Given this list of marker genes Etnppl, Vdac1, mt-Tq (mitochondrially encoded tRNA glutamine), Pdhx, Mrpl32, Dctpp1, Gsdmd, Cln8 (NCBI Gene Id 26889), Mtch2, Agk, Crot, Reep1 (receptor accessory protein 1), Eral1, Gpx1, Atp5f1a, Acsbg2, Mobp, Ndufs7, Slc30a2, Nubpl, Ndufaf5, Pet100, Bltp1, Mrpl34, Ppp1cc, Miga2, Yme1l1, Tmem177, Afg1l, Ehhadh, Stmp1, Tnrc18, Tmtc1, Hsd17b8, Grsf1, Gfm1, Ak3, Ddit4, Smad5, Slc9b2, Rida, Mavs, Eci2, Ddah2, Tmbim6, Pnpla8, Polr1g, Cyp2e1, Nme2, Aqp8, Dmgdh, Trim27, Hsd3b3, Slc25a36, 4933434E20Rik, Slc1a3, A830073O21Rik, Rap1gds1, Htra2, Pde2a, Nol3, Tmem14c, Trim34b, Vamp1, Fmc1, Coq5, Anxa10, Mrps26, Cryzl2, Txnrd2, Usp48, Wdr81 (NCBI Gene Id 192652), Pmpca, Tmem11, Timm29, Fkbp8, Secisbp2l, Aldh2, Pgs1, Slc27a1, Ldhb, Hoga1, Fastkd3, Fundc2b, Mrpl10, Pde12, Sphkap, Mgme1, Hax1, Acp6, Fdx2, Uqcr10, Tsfm, Ckb, Sting1 (NCBI Gene Id 72512), Spire1, Immp2l, Afg3l1, Atp6v1a, Nr3c1, Tmem65, Mcee, Bdh1, Tug1, Tomm70a, Got2, Slc9a1, Coasy, Slc25a53, Chchd1, Tppp, Ybey, Rilp, Rala, Tdrkh, Lgals3, Rpl35a, Rnaset2a, Acod1, Cox14, Stx17, Agmat, Cyp2d11, Dnajc11, Pmpcb (peptidase (mitochondrial processing) beta), Hspa9, Ykt6, Stard13, Ndufa4, Vdac2 (NCBI Gene Id 22334), Bcl2a1b, Ppp3ca, Cox8b, Oxct2a, Uqcc5, Mff, Atad1, Ldha, Kyat3, Ntrk1, Fkbp4, Bcl2a1d, Aifm1, Cdkn2a, Fbxw7, Timm50, Capn10, Adcy10, mt-Tm, Tfb2m, Usp15 (NCBI Gene Id 70921), Chdh, Bltp2, Aldh4a1, Zfp13 (NCBI Gene Id 240046), Nt5dc3, Mipep, Cryab, Dglucy (D-glutamate cyclase), mt-Tl2, Ccr7, Cox20, Fndc1, Isca2, Prnp, Gsk3a, Cwc15, Slc25a1, Nmnat3, Rab3d, Uba1, mt-Tf, Yjefn3 (YjeF N-terminal domain containing 3), Slc25a46, Mecr, Me1, Plin5, Sdhc, Ywhaz, Mthfd1 (methylenetetrahydrofolate dehydrogenase (NADP+ dependent), methenyltetrahydrofolate cyclohydrolase, formyltetrahydrofolate synthase), Dcps, Higd1c, Mapk3, Jtb, Ptcd1, Dhfr, Nars1, Trap1, Gstk1, Acsl5, Etfdh, Poldip2, Slc25a12, Prr5l, Azin2, Slc29a3, Slc25a22, Dbi, Fam210a, Pi4kb, Nipsnap1, Nlrp3, C330018D20Rik, Mterf1a, Srgap2, Hsd3b5, Kansl1, Afg3l2, Dhrs4, Ngb, Ambra1, Vps13a, Mapk10, Gtpbp10, mt-Nd3, Ccn6, Msra, Isoc2a, Pars2, Bri3bp, Gls2, Rab11fip5, Ciapin1 (cytokine induced apoptosis inhibitor 1), Adh5, Sdsl, Vamp8, Snca, Alkbh3, Mrps23, Hsdl2, S2bpcox16, Ucp1, Ndufa6, Mrps12, Hrk, Plgrkt, Nsun2, Dtymk, Slc25a30, Ogt, Snd1, Park7, Tpo, Cox7a2l, Slc9a6, Rab7, Cyp27b1, Mtarc1, Tardbp, Gpd1 (glycerol-3-phosphate dehydrogenase 1 (soluble)), Efhd1, Nol7, Arid4b, Pusl1, Mtrf1l, Pstk, Tst, Timm9, Pam16, Serac1, Car5b, Mrpl30, Ndufaf8, Pemt, Abcg1, Agr2, Tk2, Ndufaf2, Gpx4, Phb2, Noc3l, Dmac2, Bik, Cisd1, Aldoc, Ccs, Gsta1, Kars1, Elk1, Pyroxd2, Cstad (CSA-conditional, T cell activation-dependent protein), Mrpl13, Abcb1b (ATP-binding cassette, sub-family B member 1B, NCBI Gene Id 18669), 4930550C14Rik, Sarm1, Ctsa, Ifit3 (NCBI Gene Id 433243), Secisbp2, Akr7a5, Zfhx3, Etfrf1, Kansl2, Mrs2, Cox10, Ndufs4, Ndufb4b, Wars2, Bcl2l2, Mtg1, Gng5, Hyou1 (hypoxia up-regulated 1), Araf, ENSMUSG00000125816, Hspa5, Pisd, Mrpl16, Aco2, Top1mt, Gtpbp8, Qtrt1, Acat1, Uqcc6, Hsd3b9, Acot2, Rab11fip3, Akr1b8, Chchd3, Ugt2b37, Htd2, Smpd5, mt-Atp6, Rab38, Myoc, Pdk1, Acads, Mrm2, Ddx21, Nipsnap3b, Cox7c, Sdha, Glod4, Amt, Alkbh1, Atp5mk, Supv3l1, Pxmp2, Adap2, Adh1, Polr2b, Mrps2, 2310002L09Rik, Aars1, Fkbp10, Msrb2, Rab40b, Tshz3, Pln, Kynu, Abcd2, Gstm1, Fxn, Mmachc, Irgm1, Oas1c, Ndufc1, Gldc, Nthl1, Ier3, Adck5, Psma6, Gsdma3, Coa6, Fh1, Fam72a, Lap3 (NCBI Gene Id 66988), Uqcr11, Casp9, Fpgs, Ndufb4c, Samm50, Ecsit, Akt1, Cyp2d22, Gfm2, Neurl4, Tmem8b, Dgat2, Thop1, Rsad1, Cox17, Ntrk3, Fth1, Rfk, Slc30a7, Sod2, Sardh, Brd8, Cyp27a1, Pcbd2, Cyp11b1, Crebzf, Gsta4, Slc25a31, Bnip3l (NCBI Gene Id 97931), Pck1, Mrpl12, Prkce, Pdss1, Arg2, Gapdh, Exd2, Mrpl18, As3mt, Klc2, Braf, Dlat (NCBI Gene Id 235339), Slc16a1, Rps6ka6, Plaat3, Prelid3b, Cfap410, Aldh5a1, Nsun4, Mgst1, Pgam5, Lonp1, mt-Tg, Trnt1, AK157302, Timm8a2, Immp1l (IMP1 inner mitochondrial membrane peptidase-like (S. cerevisiae)), Cox6c2, Qtrt2, Mapk8ip1, Disc1, Tmem242, Cnr1, Mdh1, Napg, Metap1d, Cyp11b2, Emc2, Acly, Kmo, Slc25a29 (NCBI Gene Id 353077), Dck, Acsf3, Ppp6c, Apex1, Acad8, Slc25a40, 1700066M21Rik, Tmem223, Slc25a35, Akap1, Coa3, Sncb, Src, Timm17b, Mtor, Cps1, Agxt, Rars1, Rmdn2, Smim30, C030010C08Rik, Fzd9, Dnlz, Ptges2, Vasn, Mars1, Ndufa7, Ppa2, Uqcc3, Plscr3, Dcaf8, Ugt2b5, Nadk2, Gpt2, Cox6b2, Fastkd1, Cbr4, Rhoa, Gcat, Rps3 (NCBI Gene Id 52418), Asl, Adam28, Gja6, Pycr2, Nrdc, Acot9, Dnaja1, Prdx6b, App, Mrps27, Rnasel, Spr, Agxt2, Sfxn3, Nudt1, Phyhipl, Arl2bp, Slc25a48, Spmip6, Ammecr1, Tmem102 (NCBI Gene Id 380705), Ung, Chchd5, Mrpl36, Ndufb3, Mrps11, Slc25a33, Gabbr1, Nefh, Nat8f1, Ctps2, Cuta, Rab32, Kcnq3, Ywhah, Coa7, Pdss2, Drg2, Nme1, Taco1, Slc25a37, Rai14, Asb9, Trit1, Mrpl46, Brinp3, Aadat, Pccb, Ifi27l2a, Agpat5, Rab11b, Sox4, Heatr1, Nars2, Nrgn, Tusc3, Glyat, Mfsd8, Atp5po, Cyct, Coa8, Urah, Oma1, Phykpl, Slc30a9, Tmem71, Camk2a, Rxra, Kifbp, 2310061I04Rik, Dusp26, Slc25a28, Cox19, Slirp, Abcd1, Fen1, Dusp18, Pcf11, Mrpl58, Mtcp1, Mtnap1, Mapk12, Maip1, Etfbkmt, Rpl34, Bag5, Tfam, Plpbp, Arglu1, Slc25a10, Dbt, Mrpl47, Sars2, Sdhaf1, Ndufb4, Phb1, Sdhb, Agtpbp1 (ATP/GTP binding protein 1), Xpc, Slc25a51, Dld, Aars2 (alanyl-tRNA synthetase 2, mitochondrial), Atp5pf, Triap1, mt-Te, Aurkaip1, Shmt2, Slc25a54, Bckdha, Mpv17l2, Mrpl3, Spata18, Pla2g2a, Slc27a3, Higd1a, Polr2a, Dmac1, Hagh, Haao (NCBI Gene Id 71669), Polg2, Mtrf1, Mtarc2, Map2k1, Fam162a, Fsip2, Rnf144b, Otc, Samd9l, Isoc2b, Cyp1a1, Apoo (NCBI Gene Id 73714), Ncbp1, Cfap91, Gckr, Myg1, Fahd2a, Ngdn, Hif3a, Degs1l, Cisd3, Flad1, Oxct2b, Mrps35 (mitochondrial ribosomal protein S35), Ppp1r15a, Adprs, Armcx3, Acaa1b, Atp5f1e, Tcaim, Shc1, Helb, Mief1, Acbd3, Sdhaf2, Sdhaf4, Acot8, Tafazzin, Slc25a42, Hmgcl, Ogdhl, Mcur1, Tspo, Arg1, Gcdh, Dok7, Hspa1a, Clic1, Ndufb6 (NCBI Gene Id 277815), Lipe (NCBI Gene Id 71060), Mtx2, Ccnb1-ps, Nacc2, Xpnpep3, Slc35f6, mt-Cytb, Mrpl57, Hsd3b1, Traf3 (TNF receptor-associated factor 3), Pdha2, Piwil4, Ap2m1, Ckap4, Ndufa11, Sqor, Tmigd1 (transmembrane and immunoglobulin domain containing 1), Clpb, Abl1, Lyn (NCBI Gene Id 99963), Coq7, Acaca, Aldh9a1, Arhgap26, Nlrp5, Sirt5, Acsl3, Slc22a4 (NCBI Gene Id 56507), Tufm, Ckmt1, mt-Nd4 (NCBI Gene Id 98546), Sp140l2, Stard4, Thg1l, Msto1, Ndufs5, Stard7, Atp5mc3, Fem1al, Sirt4, Tbc1d15, Coq8b, Hspa1b, Ociad1, Rnaseh1, Fastkd2, Mrps6, Eln, Lyrm4, Pgk1, Lpin1, Rdh13, Ncoa4, Them7, Mtfp1, Slc11a2 (NCBI Gene Id 18174), Nme3, Eci1, Slc25a21, Gpd2, Mrpl2, Ikbke, Pla2g6, Gtpbp3, Bad (NCBI Gene Id 12015), Nudt8, Chpf, Dcakd, Ndfip2, Erbb4, Mdh2, Xrcc3, Mmaa, Mrpl28, Bcl2l11, Pacrg, mt-Tl1, Gstp1, Fastk, Rmnd1, Mrpl54, Nudt19, Nos1ap, Pmaip1, Slc25a34, Clic5, Slc8b1, Miga1, Sult4a1, Vrk2, Abca9, Fdx1, Stap1, Prdx1, Spryd4, Tbrg4, Acat2, Bak1, Parp9, Mapk8, Calr (calreticulin), Prorp, Grk2 (NCBI Gene Id 11557), S1pr4, Depp1, Bbc3, Acadl, Ivd, Chchd4, Cyp2d10, Cyp2d9, Atpaf1, P2rx7, Ubc, Ass1, Atg4d, Aass, Sqstm1, Mrpl44, Nnt, Rab4b, Atp5mj, Cyp17a1, Gsta2, Nudt13, Tmx2, Cyb5r3, Sgk1, Dhx29, Acad10, Atg9a, Mtx3, Mrps7, Nxnl1, Hmga1, Pdpr, Slc30a6, Slc27a2, Stard3, Mcl1, Mrpl51, Sox10, Acss1, Trmt5, Ndufab1, Hsp90aa1 (NCBI Gene Id 15524), Coq6, Dhx36, Tpp1, Mars2, Ndufab1-ps, Sod1, Clpx, Rdh14, Pank2, Khdc3, Casp8, Elk3, Ctsd, Atp5pd, Iars2, Emc8, Tsc22d1, Slc25a27, Coq3, Coa4, Hint2, Fundc2, Acyp2, Sfxn4, Romo1, Zbtb6, Tamm41, Cyb5b, Cavin1, Creb1, Bcl2l10, Dnajc19, Parp1, Rps15a, Pla2g4f, Fam110b, Creb3l4, Brca1, Tspoap1, Prdx5, Ndufb11, Bckdk, Rps6kb1, Abhd12, Hsp90ab1, Mrpl19, Trmt2b, Vwa8, Slc22a14, Cox5b, Tax1bp1, Car5a, Atp6v1e1, Rad51 (RAD51 recombinase), Iscu (NCBI Gene Id 66383), Mtx1, Tango2, Hkdc1, Rbfa, Polg, Atp5f1d, Oas1h, Cox7b2, Lyrm1, Csl, Hmgn5 (high-mobility group nucleosome binding domain 5), Hdhd5, Atp10d, Vps25, Pak5, Fn3k, Mpo, Ccnb1, Lypla1, Mapk9, Nelfb, Nudt9, Aldh1b1, Casq1, Atpsckmt, Parl, Hk2, Ttc5, Gclc, Ppif, Kansl3, Atp5mg, Armcx1, Idh1, Qdpr, AU015836, Map1lc3b (NCBI Gene Id 67443), Ankrd37, Sco2, Akap10, Oas1b, Txnrd3, Mrpl11, Top3a, mt-Tw (mitochondrially encoded tRNA tryptophan), Cabs1, Pex11b, Sccpdh, Bcat1, Gmppb, Hip1r, Cldn34c5, Adss2, Gatm, Abhd10, Mtln, Nt5m, Acox3, Vps54, Dmpk (dystrophia myotonica-protein kinase), Cox5a, Trabd, Gk (glycerol kinase), Cidea, Atic, Abcb8, Tert, Cybb (cytochrome b-245, beta polypeptide), Gpaa1, Acat3, Golph3, Pts, Atp5me, Bnip1, Fastkd5, Drd4, Tex10, Dhodh, Hao2, Lrrc10, Hspe1-rs1, Gsta3, Mpc1, Slc3a1, Cerk (ceramide kinase), Atp5mc2, Fitm2, Atp5f1b, Ddx28, Slc25a14, Bola3, Hspb6, Ndufa5, mt-Nd4l (NCBI Gene Id 17720), Dusp21, Slc22a3, Fem1a, Galc, Nt5c3, Mpv17, Mterf4, Ptpn1, Pla2g15, Gatc, Polr1b, Pigbos1, Slc25a20, Slc25a38, Mix23, Cars2, Dars2, Bid (BH3 interacting domain death agonist), Mxd1, Ifi27 (interferon, alpha-inducible protein 27), Sirt2, Selenoo, Tfap2c, Oprk1, Chchd7, Chat, Ndufb1, Lrpprc, Acsl4, Macrod1, Uqcrc2, Acsm2, Hsd3b8, Hspa2, Hibch, mt-Tc, Fam136a, Ddx1, Mtfmt, Nipsnap2, Dmd, Comtd1, Pdk4, Pif1 (PIF1 5'-to-3' DNA helicase), Stk11, Calm3, Timm21, Siva1, Ghitm, Plekhn1, Ambp, Ndufb8, Trp53 (NCBI Gene Id 22059), Bcl2a1c, Bcl2, Tchp, Anxa1, Nfs1, Trim14, Ppox, Mrps9, Rab35, Timm22, Cep89, Gch1, Rexo2, Twnk, Hebp2, Slc25a17, Rack1, mt-Ts2, Hccs, Snn, Pus10, 4933405O20Rik, Nt5c (5',3'-nucleotidase, cytosolic), Canx, Abhd11, Kat8, AA467197, Ddah1, Mrpl21, Nit2, Ugt1a6a, mt-Tt (NCBI Gene Id 17744), Ggnbp1, Acad12, Opa3, Nfkb1, Irgm2, Mrpl41 (NCBI Gene Id 20007), Cry2, Sfxn5, Gck (NCBI Gene Id 14624), Pdk3, Foxk2, Fbxl4, Rab8b, Rnf5, Ogdh, Polr1a, Sphk2, Dnajc30, Fam210b, Ndufb9, Dctn6, Tars3, Mrpl48, mt-Ta, Micu2 (mitochondrial calcium uptake 2), Yap1, Psen1, Dhx30, Dlst, Mrpl37, Synj2bp, Foxo3, Znfx1, Pycard, Csde1 (NCBI Gene Id 99530), Slc25a41, Fancg, Tmem160, Nudt2, Eny2, Nampt, Cyc1, Immt, Uqcrq (ubiquinol-cytochrome c reductase, complex III subunit VII), Cisd2, Grpel1, Zdhhc8 (zinc finger, DHHC domain containing 8), Pla2g4c, Qrsl1, Mrps17, Nln, Prxl2a, Raf1, mt-Ts1, Nipsnap3a, Txn1, Tstd1, Rab29, Bnip3l-ps, Timm17a, Selenon, Pitrm1, Ears2, Slc25a45, Rars2, Tmem256, Ifit3b, Glrx, Uqcrc1, Pycr1, Mtg2, Wwox, Mlycd, Atg4b, Slc25a47, Gimap8, Suclg1, Mmab, Pkm, Acacb, Pi4k2a, Acox1, Tomm34, Atg13, Aifm3, Smurf1, Hsdl1, S100a1 (NCBI Gene Id 99575), Lias, Pdpn, Ireb2, Ercc6l2, Letmd1, Cfh, Uqcrh-ps1, mt-Nd2, Mterf3, Atp5mc1, Klc3, Slc25a15, Sds, Txnrd1, Stxbp1, Mrpl45, Hdhd3, Pdp1, Dpysl2, P4ha1, Pnpt1, Ndufs8, Cfl1, Capn1, Pin4, Myo19, Ubqln5, Lyrm7, Bloc1s2, Ap3b1, Acadvl, Pcca, Aldh1l1, Oxld1, Vps35, Oas1e, Ndufb11b, Mrpl43 (mitochondrial ribosomal protein L43), Cox11, Prodh2, Mrm3, Etfa, Pld6, Mrps15, Hadha, Rsad2, Map2k2, Pet117, Grn, Pdzd8, Ndufaf7, Abat, Slc25a2, Gstz1, Agps, Surf1, Gpn1, Fdps, Prdx4, Maob, Ppargc1b, Ptrh1, Trmt10c, Ift140 (intraflagellar transport 140), Iqcn, Trub2, Nif3l1, Cox7b, Abcb10, Ethe1, Uox, Cbr2, Ptcd3 (pentatricopeptide repeat domain 3), Nox4, Cend1, Acss3, Pebp1, Dhrs2, Hsd17b4, Pyurf, Lyrm2, Slc41a3, mt-Nd1, Gstm2 (glutathione S-transferase, mu 2), Pou5f1, Atxn3 (ataxin 3), Atpaf2, Slc25a3, Zfyve1, Hscb, Spata33, Idh3g (NCBI Gene Id 15929), Eci3, Rhbdd1, Katnal1, Prdx6, mt-Tv, Serhl, Msrb3, Plcd1, Ern1, Mtus1, Higd2a, Hddc2, mt-Co1, Haus3, Trak2, Mtres1, Mettl4, Dnajc27, Mthfd1l, Cyp2u1, Cpt1a, Ndufaf4, Hibadh, Slc25a26, Cox16, Hsd3b4, Acsm1, Hars2, Ndufc2, Nsun3, Slc25a39, Mmut, Dele1, Mto1, Clybl, Tigar, Nags, Snph, Yars2, C030006K11Rik, Ech1, Sfxn2, Cyp2d26, Vps13c, Hsd3b2, Ttc19 (NCBI Gene Id 76693), Pink1, Ndufaf6, Atg5lrt, Plaat1, Akr1b10, Echdc3, Timmdc1, Mthfsl, Adck1, Rhot1, Alpl, Sh3bp5, Ide, Gps2, Dnm3, Hivep1, Cert1, Calm1, Oprm1, Glud1, Micu1, Them4, Prelid3a, Sirt3, Mapk1, Slc25a32, Acadm, Sdhaf3, Kif1b, Coq8a, Asah2, Bphl, Becn1, Pck2, Gimap3, Ngrn, Abca8b, Lactb2, Tomm7, Adsl, Oas1d, Macc1, Ndufv2, Lipt1, Usp30, Ptgr2, Tmem14a, Hspe1, Prkca, Clpp, Hlcs, Sult1c2 (sulfotransferase family, cytosolic, 1C, member 2), Naif1, Tmco1, Atad3a, Prelid2, Letm2, Uqcc4, mt-Tk, Tyms, Cox15, Them5, Mrpl23, Mthfd2l, Slc25a18, Crym, Gk2, Nos1 (NCBI Gene Id 76730), Ticam1, D2hgdh (D-2-hydroxyglutarate dehydrogenase), Mrps24, Hspd1, Guf1, Ptpmt1, Cyb5r2, Flvcr1 (feline leukemia virus subgroup C cellular receptor 1), Rab11a, Pick1, Uqcc1, Tat, Ccm2, Bclaf3, Bcat2, Ndufaf1 (NCBI Gene Id 69702), Rrm1, Vat1, Cebpzos, Irf3, Micos13, Chchd2, Rab24, Mthfs, Ociad2, Nol6 (nucleolar protein family 6 (RNA-associated)), Abhd5, Coq2, mt-Co3, Ndufb2, Polr3b, Bola1, Mcat, Tomm40, Th, Noct, Pla2g4b, Tomm6, Oxa1l, Apex2, Mycbp, Abcf2, Suox, Ndufv1, Mtch1 (NCBI Gene Id 98058), Tusc2 (tumor suppressor 2, mitochondrial calcium regulator), Cry1, Prkaca, Cs, Coa5, Cmc2, Slc25a13, Nudt6, Atcay, Uqcrh, Hspa1l, Glrx2, Vars2, Tmem126a, Gls (NCBI Gene Id 98298), Mrm1, Anxa6, Cpt2, Micu3, Cyb5a, Pnkd, Tmx1, Glyatl3, Ccdc51, Hs1bp3, Casp8ap2, Cox8c, mt-Td, Acad9, Prickle3, Psap, Spg7, Stat3, Abcc9, Nfu1, Sucla2, Slc25a16, Mrpl15, Idh2, Acaa1a, Iqce, Cpne3, Wdr26, Abcd3, Acsm4, Cyp1b1, Igtp, Slmap, Arhgap11a, Cdk1, Mat2b, Nlrx1, Gpam, Hadh, Adhfe1, Mrpl50, Star, Naxd, Gadd45gip1, Septin4, Dnajc4, Dnm1l, Ifi27l2b, Cyb5r1, Chchd10, Noa1, Casp1, Acsm3 (acyl-CoA synthetase medium-chain family member 3), Malsu1, Coq10b, Olfm4, Me3, Timm44, Spart, Lig3 (NCBI Gene Id 28083), Crat, Ifih1, Gm6559, Aldh6a1, Ogg1, Mpst, Stom, Kif5b, Ppm1j, Idh3b, Nme4, Styxl1, Shmt1, Ndufa12, Tomm40l, Armc12, Uqcc2, mt-Tp, Gk5, Cyp2b10, Ndufa9, Abcb7, Kif28, Lipt2, Cox7a1, Dact2, Pptc7, mt-Atp8, Sfxn1, Arl2, Mmadhc (methylmalonic aciduria (cobalamin deficiency) cblD type, with homocystinuria), Pus1, Ripk1, Slc39a9, Gramd4, Me2, Cdc25c, Cdk5rap1, Oxr1, Ndufa11b, Armcx6, Fis1, Slc25a25, Mrpl33, Acsm5, Tgm2, Pcx, Glyctk, Tmem135, Acot1 (acyl-CoA thioesterase 1), Cox18, Hpdl, Slc35b3, Ppp3cc (protein phosphatase 3, catalytic subunit, gamma isoform), Pex5, Mrps18a, Rmdn3, Nbr1, Tars2, Uxs1, Afg2a, Glul, Ywhag, Hadhb, Gper1, Bnip3, Sh3glb1, Mief2, Fhit, Chchd2-ps, Hmgcs2, Bco2, Epha4, Gars1, Sugct, Mfn2, Ralbp1, Atp5f1c, Sco1, Cpox, Cyp2d12 (cytochrome P450, family 2, subfamily d, polypeptide 12), Bcs1l, Tmem126b, Cmpk2, Clic4, Abhd8, Nat8l (NCBI Gene Id 68762), Ak2, Mrpl27, Ldhd, Echs1, Cnp, Ldhc, G0s2, Cox6c, Cibar1, Cyba, Ppm1m, Mrpl14, Hk3, Ptrh2, Vdac3, Phyh (phytanoyl-CoA hydroxylase), Mrpl1, Crls1, Mmp3, Rpusd4, Gatd3a, Hap1, Pdha1, Rtn4ip1, Tomm20l, Timm10, Gja1, Timm10b, Rad51c, 2310057M21Rik, Cmc4, Cycs, Trim39, Plec, Polrmt, Nenf, Slc25a24, Stoml2, Angel2, Eif2s1, Slc25a5, Prelid1, Mrpl53, Mapkap1, Mtfr1l, Dnajc19-ps, Timm13, Tomm22, Smim20, Mrpl39, Polq, Dus2, Mtfr1, Fyn, Clu, Slc25a44, Aldh7a1, Ndufa2, Gpat2 (glycerol-3-phosphate acyltransferase 2, mitochondrial), Rab1b, Cat, Sp140l1, Osgepl1, Acot10, Cyp24a1 (cytochrome P450, family 24, subfamily a, polypeptide 1), Mettl9, Primpol, Lactb, Atp5pb, Cox6b1, Mrpl38 (mitochondrial ribosomal protein L38), Auh, Oas1g (NCBI Gene Id 23960), Cox7a2, Prdx2, 1700123O20Rik, Gcsh, Ppm1k, Ssbp1, Dhrs1, Ucp2, Ube3b, Ndufa3, Neu4, Mrps25, Gdap1, Trmu (tRNA 5-methylaminomethyl-2-thiouridylate methyltransferase), Decr1, Elac2, Mrps5, Lipf, mt-Ti, Sgpp1, Rmdn1 (NCBI Gene Id 78089), Pdp2, Pacs2, Grpel2, Mrps21, Mgst3, Gfer, Mrps28, Gsk3b, Tomm5 (translocase of outer mitochondrial membrane 5), Jarid2 (NCBI Gene Id 97879), Wasf1, Cltc, Mtpap, Pdf, Rps14, Fdxr (ferredoxin reductase), Cox6a2, Isca1, Uqcrb, Pdhb, Rpusd3, Mtif3, Ank2, Ccdc90b, Cct7, Bok, Cmc1, Slc25a43, Mrpl40, Prkn, Degs1, Mrps22, Mpc2, Nit1, Col6a1, Keg1, Tmem186, Caprin2, Spata19, Dcaf5, Sdhd, Gstp-ps, Mcu, Aldh1l2, Mrps18c, Higd1b, Fars2, Eefsec, Kyat1, Bbox1, Mrps16, Rnf185, Yrdc, Tefm, Proca1, Mtif2, Casp14, Uqcrfs1, Mrpl22, Aldh18a1, Xaf1, Ak4, Ndufb5, Lrp5, Dut, Stpg1, Ndufb10, Gsr, Sirt1 (NCBI Gene Id 93759), Tcirg1, Ndufa8, Idh3a, Mrpl20, Nod2, Tatdn3, Ccdc136 (coiled-coil domain containing 136), Cyp2d34, Abce1, Aldh3a2, Dip2a, Coq10a, 1600014C10Rik, Vars1, Mettl17, Lrrc59, Mtfr2, Mrpl9, Cpt1b, Alkbh7, Fcor, Comt, Tap1, Diablo, Chchd6, Etfb, Slc25a23, Uri1, Ufl1, Acsf2, Ywhae, Fasn, Gstp3, Ago2, mt-Tr, mt-Nd6 (mitochondrially encoded NADH dehydrogenase 6), Uros, mt-Nd5, Akr1b7, Psmb4, Traf3ip3, Tdh (NCBI Gene Id 58865), Oas1a, Mrpl49, Ndufa1, Cyp2d40 (NCBI Gene Id 71754), Fate1, Pgrmc1, Huwe1, Apool, Oxsm, Ccar2, Fgr, Armc10, Mettl13, Ilf3, Rrm2b, Trim34a, Hat1, Mrps36, Dmac2l, Atp5mf, Gatb, Aco1 (NCBI Gene Id 11428), Acot7 (acyl-CoA thioesterase 7), Dna2, Suclg2, Gm2a, Hemk1, Muc20, Slc44a2, Ubiad1, Sacs, Smcp, Nr4a1 (NCBI Gene Id 15370), Ado, Fech, Slc25a4, Mrps14, Armcx2, Mapk14, Acad11, Oxct1, Ppm1h, Slc8a3, Ckmt2, Ndufv3, Cox4i1, Txn2, Atp2b4, Maff, Kcnk9, Mcub, L2hgdh, Tars1, Slc25a11 (NCBI Gene Id 67863), Ndufaf3, Trim31, Dhx32, Mlxip, Mrpl24, Gstp2, Exog, Rnaset2b, Tmem143, Palld, Iba57, Ubb, Prkcd, Echdc2, Antkmt, Snap23, Hk1, Mterf2, Mettl15, Slc25a19, Hspb7, Rpl10a, Lrrk2, Dnajc15, Lgals12, Pecr, Fads1, Mgarp, Ngfr, Nrp1, Bloc1s1, Bdnf, Idi1 (NCBI Gene Id 319554), Mccc2, Acaa2 (acetyl-CoA acyltransferase 2), Ndufa10, Mrpl42, Aifm2, Abhd4, Mrps33, Gad1, Trafd1, Atp5if1, Acot11, Git1, Lrrk1, Acadsb, Syne2, Gprc5c, Maoa, Adck2, Agpat4 (NCBI Gene Id 68262), Mul1, Bcl2l1, Abca12, Zmiz2, Fam124b, Mrps30, Bax, Calm2, Sptlc2, Myl10, Mutyh, Oat, Gm4952, Tomm20, Bag3, Kank2, Tmem70, Fahd1, Marchf5, Mterf1b, Armc1, Mt3, Psmb6, Sp140, Mrpl35, Perp, Ndufb7, Bckdhb (NCBI Gene Id 12040), Hsd3b6, Cox6a1, Naxe (NAD(P)HX epimerase), Mtrfr, Rab5if, Stub1 (STIP1 homology and U-Box containing protein 1), Mccc1, Dguok, Prdx3, Abcc12, Cox8a, Aim2, Pfdn4, Zfp217, Sesn2, mt-Rnr2, Mrpl17, Alas2, Dynll1, Tspo2, Atp2a1, Lars2, Bcl2l13, Eya2, Ppp1ccb, Alas1, Mmp2, Moap1, mt-Rnr1, Hcls1, Ctsb, Cpt1c, Sord, Misfa, Tfap4, Fundc1, Ctu1, Acot13, C1qbp, Timm8b, Rhot2, Fbxo7, Letm1, Ndufs6, Cox4i2, Smim26, Tfb1m, Pdk2, Hsd17b10, Dnaja3, Mrpl55, Sars1, Trak1, Ndufs1, Ndufa13, Mrrf, Gabarapl1, Pinx1, Abcg2, Acsl1, Dao, Mpg, Micos10, Mrpl4, Mrps31, Prss35, Rcc1l, Atf2, Abcb6, Prodh, Abhd6, Hebp1, Acsl6, Mthfd2, mt-Co2, Casp4, Kcnq2, Ndufs3, Herc2, Amacr, Oxnad1, Esr2, Trmt10b, Ppp2r2b, Gykl1, Mrpl52, Zbed5, Ftmt, Siah3, Opa1, Hsh2d, Ppp3r2, Cyrib, Glrx5, Oas1f, Mfn1, Bcl2a1a, Foxred1, Dhtkd1, Mrps18b, Ldhal6b, Pfdn2, Mrps34, Flvcr2, Smdt1 (single-pass membrane protein with aspartate rich tail 1), Gm14137, Ndufs6b, Mpv17l, Timm8a1, Coq9, Mettl8, mt-Tn, Ptcd2, mt-Th, Ucp3, Card19, Mrps10, Ndufs2, Slc44a1, Scp2, Dap3, Ptgr3, Gtf3c4, Cyp11a1, Timm23, Coq4, Nme6, Hars1 (NCBI Gene Id 15115), mt-Ty, Endog, here is a description of the gene set: species: Mus musculus A semiautonomous, self replicating organelle that occurs in varying numbers, shapes, and sizes in the cytoplasm of virtually all eukaryotic cells. It is notably the site of tissue respiration. Mouse Gene Set: GOCC_MITOCHONDRION